The following is a description of a gene set: Genes down-regulated in T cells: control (0h) versus IL21 treatment for 6h. species: Homo sapiens Interleukin-21 (IL-21) is a pleiotropic cytokine that induces expression of transcription factor BLIMP1 (encoded by Prdm1), which regulates plasma cell differentiation and T cell homeostasis. We identified an IL-21 response element downstream of Prdm1 that binds the transcription factors STAT3 and IRF4, which are required for optimal Prdm1 expression. Genome-wide ChIP-Seq mapping of STAT3- and IRF4-binding sites showed that most regions with IL-21-induced STAT3 binding also bound IRF4 in vivo, and furthermore, revealed that the noncanonical TTCnnnTAA GAS motif critical in Prdm1 was broadly used for STAT3 binding. Comparing genome-wide expression array data to binding sites revealed that most IL-21-regulated genes were associated with combined STAT3-IRF4 sites rather than pure STAT3 sites. Correspondingly, ChIP-Seq analysis of Irf4_/_ T cells showed greatly diminished STAT3 binding after IL-21 treatment, and Irf4_/_ mice showed impaired IL- 21-induced Tfh cell differentiation in vivo. These results reveal broad cooperative gene regulation by STAT3 and IRF4. from publication Kwon H, Thierry-Mieg D, Thierry-Mieg J, Kim HP, Oh J, Tunyaplin C, Carotta S, Donovan CE, Goldman ML, Tailor P, Ozato K, Levy DE, Nutt SL, Calame K, Leonard WJ (PMID 20064451) Human Gene Set: GSE19198_CTRL_VS_IL21_TREATED_TCELL_6H_DN, and this is the list of marker genes: PLEKHA2, PREX1, THRAP3, SAT1, C1QB, MACROH2A1, GAB3, ETS2, BIN2, RASA1, TFPI, FCGR3B, WASF1, ZBTB16, TANGO2, SC5D, RGL1, NUPR1, PITHD1, SNCA, AMIGO2, AP2A2, SLC31A2, TLR5, FBXO34, RNASE4, SH3D21 (SH3 domain containing 21), ZFYVE21, PARP15, ABLIM3, TAF6L, CD180, CSNK2A2, FLOT1 (NCBI Gene Id 10211), RDH10, POR, RNF168, TCF12, RUFY1, SOCS6, MS4A6E, GLMP, KDM7A, PRUNE1, EPS8, STX7, AMDHD2, PIK3R5, SH3PXD2B, AZI2, SHMT1, FKBP5, PIK3IP1, CNDP2, CAPN1, HYLS1, FMN1 (formin 1), DUSP3, RLF, KIF13B, TSC22D3, SLC7A7, IL18R1, TMEM37, ERC1, RMDN3, TRIM37, MAP3K21, WDR81, PDK4, ARL8A, SRPX, ZNF395, SKI, SIGLEC1, DHDH, PLEKHO2, MAML2, MSL2, SETD2, HTRA1, TPD52L2, DVL2, MYO7A, PMP22, PTGR3, GLUL, CYTH3, MOAP1, RHOBTB1, PLS1, PELI1, SLC16A10 (solute carrier family 16 member 10), C2, MAN1A1, TLE3, TMEM198B, MERTK, IL10, LINC01003, TAGAP (T cell activation RhoGTPase activating protein), TFCP2L1, MAP3K8, ELL2, SNTB2 (NCBI Gene Id 6645), RNF38, SAMSN1, SEPTIN10, FANCI, USF2, DIP2B, DDX24, SPRING1, STK40, KIF16B, SUSD1, CCL26 (NCBI Gene Id 155403), YPEL2, N4BP1, DAAM2, VSIG4, LHFPL2, YTHDF3, CUEDC1, VAV3, GNPDA1, RASSF2, PSME4, MPP1, SAP30, RAB5B, GGA2, LILRB5, STK26, ADAP2, ADAM9, TOPORS, VWA5A, ARID5B, IGFBP4, PCED1B, ALOX15B, RIMOC1, CELF6, MFSD1, TNS1, CMKLR1, RNF135, IRAK3, TBC1D16, FAH, LACC1, GADD45B, HECA, RADX, GBGT1, QKI, DIRC3, STARD13, RALGDS, DTX3L, P2RY12, GTF2IRD1, ENTR1, STX6, RPL37A, FRAT1, PALS1, SNX27, SGK3, CYP19A1, SNX1, FCHO2, GAB2, CRYL1, PLOD2, GBE1, PER1, TPST1, H2AC25, HMGB3P1, USP54, CERS2, TLR2, TBC1D14, ST8SIA4, DUSP1, MTMR4, PIK3C2A (phosphatidylinositol-4-phosphate 3-kinase catalytic subunit type 2 alpha), PLEKHB2 (NCBI Gene Id 55041), GLDN, LARP4 (NCBI Gene Id 113251), LDLRAD3, CCDC97, ITSN1, SSH2 (NCBI Gene Id 85464), SECTM1, ADORA3